The following is a description of a gene set: from publication Welcsh PL, Lee MK, Gonzalez-Hernandez RM, Black DJ, Mahadevappa M, Swisher EM, Warrington JA, King MC (PMID 12032322) studied in species Homo sapiens Human Gene Set: WELCSH_BRCA1_TARGETS_DN Down-regulated by induction of exogenous BRCA1 in EcR-293 cells Loss of function of BRCA1 caused by inherited mutation and tissue-specific somatic mutation leads to breast and ovarian cancer. Nearly all BRCA1 germ-line mutations involve truncation or loss of the C-terminal BRCT transcriptional activation domain, suggesting that transcriptional regulation is a critical function of the wild-type gene. The purpose of this project was to determine whether there is a link between the role of BRCA1 in transcriptional regulation and its role in tumor suppression. We developed a cell line (in which BRCA1 can be induced) and used microarray analysis to compare transcription profiles of epithelial cells with low endogenous levels of BRCA1 vs. transcription profiles of cells with 2-4-fold higher induced levels of expression of BRCA1. At these levels of expression, BRCA1 did not induce apoptosis. Undirected cluster analysis of six paired experiments revealed genes, the expression of which was altered significantly and consistently by BRCA1 induction. Expression of genes was altered more than 2-fold. BRCA1-regulated genes associated with breast tumorigenesis included the estrogen-responsive genes MYC and cyclin D1, which are overexpressed in many breast tumors; STAT1 and JAK1, key components of the cytokine signal transduction pathway; the extracellular matrix protein laminin 3A; ID4, an inhibitor of DNA-binding transcriptional activators, which in turn negatively regulates BRCA1 expression; and the prohormone stanniocalcin, expression of which is lost in breast tumor cells. Coordinated expression of BRCA1 with ID4 and with stanniocalcin was confirmed in primary breast and ovarian tumors., and this is the list of marker genes: PSMD1, RXRA, TCOF1, NME3, KDM5C, CCND1, SEC24C, NUP188, LMNB2, FARSA, PMPCA, TAF1C, EZR, MCL1, POLD1, MRPS12, DDX10 (NCBI Gene Id 1662), CCNE1, DUSP1, DNAJC7, NARS1, DDX11, NAA80, MGST1, HK1, RABEPK, PPAT, NOS2 (NCBI Gene Id 4843), SMARCA4, EDC4, U2AF1, NDRG1, HSF1, HRAS, RPIA, PPM1F, CTPS1, EIF2B2, AP3D1 (adaptor related protein complex 3 subunit delta 1), SRPK1 (SRSF protein kinase 1), CDK4, UBAP2L, VDAC1, PRKACA, MANF, SOX4, POLG, MCM2, MTHFD1, EMG1, DHCR24, SF3A3, CYC1, AIMP2, SLC39A7, SAFB, MOGS, FASN, SON, PKN1, RASSF7, MLEC, P2RX4, CDC25B, SLC6A8, DNTTIP2, POLRMT, ANXA11, RRP1B, SMAD6, SKIC2, BRD2, SCAP, NSDHL, HCFC1, PWP2, SCRIB, CHAF1A (chromatin assembly factor 1 subunit A), NUP214, SLC1A5, FDFT1, AGPAT2, DANCR, SLC29A1, H4C3, RARS1, FKBP4, HDLBP, SLC19A1, CDC123, USP5 (NCBI Gene Id 8078), PIEZO1, SLC1A3 (solute carrier family 1 member 3), GTF3C2, CDC37, UBL4A, KAT2A, NOLC1, ALG3, STC1, DDT, CLTA, XRCC5 (NCBI Gene Id 7520), EIF3B, BMS1, NMT1, SSRP1, KRT6B, HSPA1B, CKAP4, APEX1, SRSF11, GAL, GCSH, ATIC, GALK1, NPIPB3, PABPC4, SNRNP70, BYSL (bystin like), HSP90B1 (heat shock protein 90 beta family member 1), CCDC85B, TRAP1, FGFR3, BOP1, EIF3E, CHD4, SSBP1, PRRC2A, RCC1, H1-10, SLC7A5 (solute carrier family 7 member 5), SRM, SNRPA1, MYC, CAD, EIF4H, PDCD11, RAE1, SF3B2, PHKG2